The following is a description of a gene set: SMAC, XIAP-regulated apoptotic response studied in species Homo sapiens Human Gene Set: REACTOME_SMAC_XIAP_REGULATED_APOPTOTIC_RESPONSE, and this is the list of marker genes: SEPTIN4, CYCS, CASP3, CASP9, APAF1, CASP7, XIAP (X-linked inhibitor of apoptosis), DIABLO